Given this list of marker genes COA7, DNAJC10, TXN, PGK1, PDIA6, STAB1, TXNRD1, TMX4, TXN2, TMX3, GFER, TXNDC12, SCO2, GSTO2, TXNDC8, GLRX2, PDIA5, TXNDC17, PDIA3, NXN, STAB2, TXNDC5 (NCBI Gene Id 81567), QSOX1, TXNRD3, CCS, GLRX, TXNL1, P4HB, GSTO1, TXNRD2, SELENOT, ERO1A, QSOX2, ERO1B, TMX1, CHCHD4, CLIC3, PDIA4, TMX2, GSR, PDIA2, TXNDC2, here is a description of the gene set: Human Gene Set: GOMF_DISULFIDE_OXIDOREDUCTASE_ACTIVITY studied in species Homo sapiens Catalysis of the reaction: substrate with reduced sulfide groups = substrate with oxidized disulfide bonds.